Given this list of marker genes VIM, GMFB, PURA, RAC1, PGF, here is a description of the gene set: Human Gene Set: CALVET_IRINOTECAN_SENSITIVE_VS_REVERTED_UP from publication Calvet L, Geoerger B, Regairaz M, Opolon P, Machet L, Morizet J, Joseph JM, Elie N, Vassal G (PMID 16501609) species: Homo sapiens In vivo neuroblastoma (NB) xenograft model, resistant to the DNA-topoisomerase I inhibitor irinotecan (CPT-11), has been established to study resistance mechanisms acquired in a therapeutic setting. Common mechanisms of resistance were not involved in this resistance. Thus, we compared the gene expression profiles of sensitive, resistant, and reverted tumors using cDNA expression arrays. Expression of selected transcripts was confirmed by quantitative real-time PCR. We found that pleiotrophin (PTN), a heparin-binding growth factor, was the only gene significantly affected: PTN gene expression was downregulated in all resistant tumors (8-14-fold) as compared to sensitive tumors, and was increased (2-4-fold) in all reverted tumors as compared to resistant tumors. PTN thus appeared to be a likely candidate gene associated with resistance to CPT-11 in this in vivo model. To investigate the direct implication of PTN in NB, we transfected two NB cell lines with RNA interferences in order to silence PTN. PTN failed to demonstrate implication in resistance to CPT-11 in vitro but could influence sensitivity to CPT-11 exclusively through an in vivo mechanism. Indeed, vasculature was significantly enhanced in resistant NB xenografts compared to sensitive and reverted xenografts, and we suggest that PTN is acting in our resistant in vivo NB model as an angiostatic factor. Genes up-regulated in neuroblastoma xenografts: resistant vs those that reverted to be sensitive to the topoisomerase inhibitor irinotecan.